Given this list of marker genes LHX3, POU1F1, KIAA0753, SRPX2, SOX3, FOXA2, CDON, PROP1, SMAD2, GPR161, PUF60 (NCBI Gene Id 22827), GLI2, DYRK1A, ADGRG1, PROKR2, ERF, WDR11, MTHFR, ROBO1, VANGL2, OTX2, PI4KA, HESX1, TBX3 (NCBI Gene Id 91834), LHX4, here is a description of the gene set: Abnormal development of the neurohypophysis during embryonic growth and development. Human Gene Set: HP_POSTERIOR_PITUITARY_DYSGENESIS species: Homo sapiens Posterior pituitary dysgenesis